The following is a description of a gene set: Mouse Gene Set: KRISHNAN_FURIN_TARGETS_DN species: Mus musculus West Nile virus (WNV), and related flaviviruses such as tick-borne encephalitis, Japanese encephalitis, yellow fever and dengue viruses, constitute a significant global human health problem. However, our understanding of the molecular interaction of such flaviviruses with mammalian host cells is limited. WNV encodes only 10 proteins, implying that it may use many cellular proteins for infection. WNV enters the cytoplasm through pH-dependent endocytosis, undergoes cycles of translation and replication, assembles progeny virions in association with endoplasmic reticulum, and exits along the secretory pathway. RNA interference (RNAi) presents a powerful forward genetics approach to dissect virus-host cell interactions. Here we report the identification of 305 host proteins that affect WNV infection, using a human-genome-wide RNAi screen. Functional clustering of the genes revealed a complex dependence of this virus on host cell physiology, requiring a wide variety of molecules and cellular pathways for successful infection. We further demonstrate a requirement for the ubiquitin ligase CBLL1 in WNV internalization, a post-entry role for the endoplasmic-reticulum-associated degradation pathway in viral infection, and the monocarboxylic acid transporter MCT4 as a viral replication resistance factor. By extending this study to dengue virus, we show that flaviviruses have both overlapping and unique interaction strategies with host cells. This study provides a comprehensive molecular portrait of WNV-human cell interactions that forms a model for understanding single plus-stranded RNA virus infection, and reveals potential antiviral targets. from publication Krishnan MN, Ng A, Sukumaran B, Gilfoy FD, Uchil PD, Sultana H, Brass AL, Adametz R, Tsui M, Qian F, Montgomery RR, Lev S, Mason PW, Koski RA, Elledge SJ, Xavier RJ, Agaisse H, Fikrig E (PMID 18690214) Genes down-regulated in naive T lymphocytes lacking FURIN: Cre-Lox knockout of FURIN in CD4+ cells., and this is the list of marker genes: Rpf1, Senp8, Zfp385c, Oplah, Ptgr2, Tspan9, Lepr, Ncmap, Kcnip2, Apol9b